The following is a description of a gene set: studied in species Homo sapiens from publication Lund R, Aittokallio T, Nevalainen O, Lahesmaa R (PMID 14607935) Th1 and Th2 cells arise from a common precursor cell in response to triggering through the TCR and cytokine receptors for IL-12 or IL-4. This leads to activation of complex signaling pathways, which are not known in detail. Disturbances in the balance between type 1 and type 2 responses can lead to certain immune-mediated diseases. Thus, it is important to understand how Th1 and Th2 cells are generated. To clarify the mechanisms as to how IL-12 and IL-4 induce Th1 and Th2 differentiation and how TGF-beta can inhibit this process, we have used oligonucleotide arrays to examine the early polarization of Th1 and Th2 cells in the presence and absence of TGF-beta after 0, 2, 6 and 48 hours of polarization. Genes up-regulated in CD4 T cells: untreated (0h) versus activated by anti-CD3 and anti-CD28 and then stimulated by IL-12 (2h). Human Gene Set: GSE2770_UNTREATED_VS_IL12_TREATED_ACT_CD4_TCELL_2H_UP, and this is the list of marker genes: JAK1 (Janus kinase 1), TAF2, RPS11, LIN7A, NCOA4, VCL, DMXL2, RNASE2, ADD3, DGAT1, PTOV1, ACVR1B, MTMR1, VNN2, STAT3, SULT1B1, MICU1, SBNO2, TLR2, CNTN6, ANP32A, LSM6, SYCP2 (synaptonemal complex protein 2), HAL, TPST1, SCP2, MGAM (NCBI Gene Id 8972), CEACAM4, UBA7, TREX1, PACSIN2, ATP5MJ, TMBIM6, PKN2, TSPAN2, CECR7, MPG, PSMB4, PITPNM1, STIM1, RPL27, GRN, TATDN2, MTHFS, RAPGEF2, SRF, TAGLN2, DSTYK, SCO2, ZMYM2, EVI2B, CCN3, TMT1A, CLASRP, SFN, ARHGEF6, MAN2B2, MYH9, NCAPD2, RPL29, MYO5A, AOAH, DGCR2, SULT1A1, CXCR1, IRF3, KATNIP, SCAP, DNAJB1, SRSF5, PDE6D, CS, HDAC5, FCHO1, CBX7, AOC2 (amine oxidase copper containing 2), MEGF9, PRPS2 (NCBI Gene Id 5634), POLR2F, ATP5PO (NCBI Gene Id 539), MSL1, GANAB, S1PR4, CALCOCO1, SLC9A1, STK24, VPS13B, LMO2, CLPTM1, H4C3, RTF1, ST6GALNAC2, RPL11, NPTN, DAPK2, PCNX1, GNAS, NAP1L1, FAM120A, EIF4G2, PPP1R12B, AOC3, GAA (NCBI Gene Id 2548), PBXIP1, CRIP1, MAP3K5, ZBED1, PYGL, GBA1, RPA1, GDE1, CDKN2D, RAF1, ASAH1, AQP9, SRPK1 (NCBI Gene Id 6732), CHI3L1, UPF3A, DOCK2, ATP6V0A2, AGER, LCP1, OAT, FLII, ALDH6A1, VBP1, S100A4, S100A12, PGLYRP1, SPTAN1, F13A1 (coagulation factor XIII A chain), CDK19, ZNF185, MAP3K3, BEST1, CLSTN1, ZSCAN26, RABAC1, LYZ, DYRK2, PINK1, INTS1, OSBPL8, FCAR, DLGAP4, ITPK1, MAN2A2, SYNE2, AGPAT1, PTGS2, TOB1, BBLN, XPO6, PRKDC, TIMP2, CUL4B, XRCC1, FKBP5, ANAPC5, YIPF1, SIVA1, NDUFAF1, PIGB, GAS7, IQGAP1, ATP5MC3, FRY, GRAMD1B, CCPG1, TBC1D1, FGL2, STAT5B, IQGAP2, UCP2, BASP1, KCNQ1, CPNE3, ZBTB16, BAD, MPPE1, HAT1, ALOX15, LCAT, NEU1, CDIPT, SIPA1L1, PEX19, ABHD2, SMS, ZNF516, FBXL5, RPL38, DCTN3, TMX4, EPHB4, CAT, ZNF467, ACP3, HMGB1, CDK14